Given this list of marker genes TULP4, CIAO2B, HSD11B1, PIK3R1, SCIN, MXD1, AGO2, CPA3, UGGT1 (UDP-glucose glycoprotein glucosyltransferase 1), SLC43A3, EIF2S3, LTB, MYCN, TRGC1, here is a description of the gene set: studied in species Mus musculus Genes up-regulated by overexpression of MAD1 in primary thymocytes from RAG2 knockout mice. Human Gene Set: IRITANI_MAD1_TARGETS_UP Activated lymphocytes must increase in size and duplicate their contents (cell growth) before they can divide. The molecular events that control cell growth in proliferating lymphocytes and other metazoan cells are still unclear. Here, we utilized transgenesis to provide evidence suggesting that the basic helix-loop- helix-zipper (bHLHZ) transcriptional repressor Mad1, considered to be an antagonist of Myc function, inhibits lymphocyte expansion, maturation and growth following pre-T-cell receptor (pre-TCR) and TCR stimulation. Furthermore, we utilized cDNA microarray technology to determine that, of the genes repressed by Mad1, the majority (77%) are involved in cell growth, which correlates with a decrease in size of Mad1 transgenic thymocytes. Over 80% of the genes repressed by Mad1 have previously been found to be induced by Myc. These results suggest that a balance between Myc and Mad levels may normally modulate lymphocyte proliferation and development in part by controlling expression of growth-regulating genes. from publication Iritani BM, Delrow J, Grandori C, Gomez I, Klacking M, Carlos LS, Eisenman RN (PMID 12234922)